Given this list of marker genes Enpp1, Kcna1, Kcnip3, Abcc6, D2hgdh, Cd14, Snca, Entpd6, Thbs1, Cnga3, Bmp6, Plcg2, Ank3, Ryr2, Slc41a1, Smpd3, Kcnc2, Fbp1, Mdm2, Fgf23, Tnfrsf11b, Ryr3, Kcnj1, Slfn14, here is a description of the gene set: Mouse Gene Set: GOBP_RESPONSE_TO_MAGNESIUM_ION studied in species Mus musculus Any process that results in a change in state or activity of a cell or an organism (in terms of movement, secretion, enzyme production, gene expression, etc.) as a result of a magnesium ion stimulus.